The following is a description of a gene set: Reactome Pathway: Gene and protein expression by JAK-STAT signaling after Interleukin-12 stimulation part of: Interleukin-12 signaling Experiments using human cord blood CD4(+) T cells show 22 protein spots and 20 protein spots, upregulated and downregulated proteins respectively, following Interleukin-12 stimulation (Rosengren et.al, 2005). The identified upregulated proteins are: BOLA2, PSME2, MTAP, CA1, GSTA2, RALA, CNN2, CFL1, TCP1, HNRNPDL, MIF, AIP, SOD1, PPIA and PDCD4.<br>And the identified downregulated proteins are:<br>ANXA2, RPLP0, CAPZA1, SOD2, SNRPA1, LMNB1, LCP1, HSPA9, SERPINB2, HNRNPF, TALDO1, PAK2, TCP1, HNRNPA2B1, MSN, PITPNA, ARF1, SOD2, ANXA2, CDC42, RAP1B and GSTO1. species: Homo sapiens, and this is the list of marker genes: GSTA2, TCP1, PDCD4, HNRNPA2B1, MIF, HNRNPF, RPLP0, LCP1, CA1, ARF1, SNRPA1, MSN, IFNG, CAPZA1, PSME2, BOLA2, HNRNPDL, SOD2, PITPNA, PAK2, CNN2, ANXA2, SOD1, SERPINB2, RAP1B, STAT4, LMNB1, PPIA, TALDO1, MTAP, CFL1, RALA, IL10, AIP (NCBI Gene Id 9049), CDC42, HSPA9 (heat shock protein family A (Hsp70) member 9), GSTO1